The following is a description of a gene set: species: Mus musculus The hydroxylation of peptidyl-proline to form peptidyl-hydroxyproline. Mouse Gene Set: GOBP_PEPTIDYL_PROLINE_HYDROXYLATION, and this is the list of marker genes: P4ha2, P4ha1, Egln2, P4hb, Ogfod1, Ero1b, Crtap, Prdx4, P3h2, Ero1a